The following is a description of a gene set: Sle2c1 is an NZM2410-derived lupus susceptibility locus that induces an expansion of the B1a cell compartment. B1a cells have a repertoire enriched for autoreactivity, and an expansion of this B cell subset occurs in several mouse models of lupus. Here we showed that expression of Sle2c1 enhances NZB cellular phenotypes that have been associated with autoimmune pathogenesis. A combination of genetic mapping and candidate gene analysis presents Cdkn2c, a gene encoding for cyclin kinase inhibitor p18INK4c (p18), as the top candidate gene for inducing the Slec2c1 associated expansion of B1a cells. A novel SNP in the Cdkn2c promoter is associated with a significantly reduced Cdkn2c expression in the splenic B cells and B1a cells from Sle2c1-carrying mice, which leads to defective G1 cell cycle arrest in splenic B cells and increased proliferation of Pc B1a cells. As cell cycle is differentially regulated in B1a and B2 cells, these results suggest that Cdkn2c play a critical role in B1a cell self renewal, and that its impaired expression leads to an accumulation of these cells with high autoreactive potential. species: Homo sapiens Human Gene Set: GSE23114_PERITONEAL_CAVITY_B1A_BCELL_VS_SPLEEN_BCELL_DN from publication Xu Z, Potula HH, Vallurupalli A, Perry D, Baker H, Croker BP, Dozmorov I, Morel L (PMID 21543644) Genes down-regulated in B lymphocytes from: peritoneal cavity versus spleen., and this is the list of marker genes: VCP, GATA3, GCSH, PSMB3, WDR43, METTL1, FH, NFATC1, DLEU1, ABCF2, TUBA1B, SQLE, FAM216A, AK2, IMMT, ATP5MC1, DIMT1, PSMB6, HNRNPDL, RPA2 (replication protein A2), NELFE, ELMO1, SUSD6 (NCBI Gene Id 9766), HSPH1, CD9, WNK1, EIF3J, PKM, DUSP6, JRKL, LAMP3, PWP1, LIG4, NUTF2, SRM, CCDC86 (NCBI Gene Id 79080), PSMB5, SHMT2, PRR3, HPS5, ZNF200, SNRPC, FUS, RPN2, RGS10, PGM1, DDX18, CD28, YWHAE, DHCR24, FKBP2, USP14, PA2G4, ATP6V1A, MTA1, DLC1, GTF2E2, UBE2G2, ATP10D, TMEM243, PPT1, POP1, RIPK2, POLR2G, GFUS, PNP, HCCS, ENO1, FARSA, BCL2L11, AATF, TM9SF1, CD47, IL1RAP, GHITM, HPRT1, TAF1B, ALG3, PPID (peptidylprolyl isomerase D), NPM1, IGSF3, C5orf22, HNRNPF, IL1R1, NUFIP1, NHP2, MTREX, OSGEP (O-sialoglycoprotein endopeptidase), NUP88, UQCR11, PPP1CC, SRGN, RPA3, TCTN3 (tectonic family member 3), DCUN1D4, HSPBP1, GAD1, IL18RAP (NCBI Gene Id 8807), RAB27A, UBE2D1, POP4, SPINT2, SP3, BET1, ITPA, FADD, AFAP1, QDPR, ZNF354A (NCBI Gene Id 6940), NME1, MAPKAPK3, NFE2L3, TARBP2, CAPZA2, EIF4G3, GTPBP6, NEMP1 (nuclear envelope integral membrane protein 1), GSDME, TNF, TIPARP, DBI, TIMM17A, MIF (macrophage migration inhibitory factor), SLC1A5, IL18R1, HYOU1, PDHB, NFKB1, HNRNPA3 (NCBI Gene Id 220988), SS18L1, LAMA2, RUNX1, HOMER1, EIF4A1, MARS1, TXN, MYDGF, VIM, ATP5MG, LPCAT1, SSRP1, KDELR2, RFC4, PDIA3, PARP1, SREBF2 (NCBI Gene Id 6721), PSMD1 (NCBI Gene Id 5707), PDCD2, CFLAR, LPL, PPP2CA, STT3A, ADSL, SMS, UBA2, NOL7, NPM3, EIF3I, GCLM, TRAF1, MAMLD1, MLEC, CPSF4, HSP90AB1, CANX, SKIC2, NDEL1, SERPINB2, NOP56, ADARB1, EVI5, UNG, ADAM19, PSMD7, HAUS7, SCAMP3, CYP51A1, BRD8, EXOC3, MTAP, AMD1, R3HDM1, TEX261, HSBP1, PDIA5, SRR, NCOR2, NUP133, LRRFIP1, DUSP5, NFYA, CDK4, MBOAT7, ATP1B3, PSME3, NT5E, SLC25A5, NCKAP1, SUCLA2, ZNRD2